The following is a description of a gene set: CD4 T cell help is critical for both the generation and maintenance of germinal centers, and T follicular helper (TFH) cells are the CD4 T cell subset required for this process. SAP (SH2D1A) expression in CD4 T cells is essential for germinal center development. However, SAP-deficient mice have only a moderate defect in TFH differentiation as defined by common TFH surface markers. CXCR5+ TFH cells are found within the germinal center as well as along the boundary regions of T/B cell zones. Here we show that germinal center associated T cells (GC TFH) can be identified by their co-expression of CXCR5 and the GL7 epitope, allowing for phenotypic and functional analysis of TFH and GC TFH populations. Here we show GC TFH are a functionally discrete subset of further polarized TFH cells, with enhanced B cell help capacity and a specialized ability to produce IL-4 in a TH2-independent manner. Strikingly, SAP-deficient mice have an absence of the GC TFH subset and SAP- TFH are defective in IL-4 and IL-21 production. We further demonstrate that SLAM (Slamf1, CD150), a surface receptor that utilizes SAP signaling, is specifically required for IL-4 production by GC TFH. GC TFH cells require IL-4 and IL-21 production for optimal help to B cells. These data illustrate complexities of SAP-dependent SLAM family receptor signaling, revealing a prominent role for SLAM receptor ligation in IL-4 production by germinal center CD4 T cells but not in TFH and GC TFH differentiation. species: Homo sapiens Human Gene Set: GSE21379_WT_VS_SAP_KO_TFH_CD4_TCELL_DN Genes down-regulated in CD4 follicular helper T cells (Tfh) with SH2D1A knockout versus wildtype Tfh cells. from publication Yusuf I, Kageyama R, Monticelli L, Johnston RJ, Ditoro D, Hansen K, Barnett B, Crotty S (PMID 20525889), and this is the list of marker genes: ZBTB20 (zinc finger and BTB domain containing 20), LIG3, CAPSL, LDHB, CD86, BAMBI (NCBI Gene Id 25805), NR3C2, RNF144A, ATF7IP (activating transcription factor 7 interacting protein), UNC5CL, DPP4, B3GNT5 (UDP-GlcNAc:betaGal beta-1,3-N-acetylglucosaminyltransferase 5, NCBI Gene Id 84002), HLA-DRB1, STING1 (NCBI Gene Id 340061), RNF122, STOX2, ZNF329, GCNT1, CENPV, MYL10, TMEM74, PNISR, ELL, TRPV2, ARHGAP30, GLRX, RUNDC3B, NEDD9, GRIA3, TOX3, CLCF1, CILK1, PRR13, MAT2A, TIMP2, VNN1, GIMAP7 (GTPase, IMAP family member 7), RNF217, NECAB1, ADGRL1, SHISA5, RHOQ, NPAS3, GCSAM, REPS1, LTB, MX2, CFTR, MAF, ZBTB16, CD163, CCL5, SPATA13, CYP4V2, ENSG00000267882, MFSD8, IL16, FRYL, NCF4, SELL, OSGIN2, ANXA9, SFI1, PPP6R3, CD1D, EPHA6, FZD6, IRF5, IGF2R, TSC1, ST6GALNAC5, ITGB7, CNGB3, ZFP2, CHD6, PEAK1, HSD17B7, NDN, PML, JADE2, VASN, HSH2D, LMOD3, ICAM1, SIPA1L3, ANKRD39, CCL4, FSD2, MS4A6A, RSF1, RGS2, OASL, IFI44, CD244, AMY2A, GIGYF1, FAM110B, NCOA1, FNBP1, MMP11, BEND5 (NCBI Gene Id 79656), CYRIA, IFIT1, RTP4, MCOLN3 (NCBI Gene Id 55283), NLRP10, KCNQ5, NRXN1, KMT2A, PADI4, KLHL4, ADGRG6, RAI1, TTC19, CD52, SNX29, PDP2, GRB10, HNF4A, CNRIP1, HLA-DQA1, NOTCH2, KIF21B, RELB, UBP1, ZBTB4, TTC12, DNAH8, RSAD2, SYNE2, SCUBE3, RINL, CDK12, IGKC, TRAF3IP2, SLC35D2, IGDCC4 (immunoglobulin superfamily DCC subclass member 4), MLPH, AFP, GBP6, HAPSTR1, OSBPL3, PHF21B, CAMK1D, NEFH, BACH1, IKZF1, IFIT1B (interferon induced protein with tetratricopeptide repeats 1B), MIR99AHG, ACOT11, AIRN, NBEA, CREBRF, MDGA2, CPN2, PIK3C2A, BRDT, RPL34, JCHAIN, SNHG8, CDC14B, TMBIM4, CCDC25, FBXW4, GIT2 (GIT ArfGAP 2), LGALS4, HLA-DOB, MPPED2, ERN1, CHDH, LINC00511, CLNK, PLAC8, NECTIN4, CCN3, GBP7, MARCKS, BCORL1, DMXL2, MC5R, LPIN1, AK4, HLF (HLF transcription factor, PAR bZIP family member), IFI27L2, PINK1, NLGN2, TNFRSF18, IFFO2, CXorf58, LHCGR, WDR35, TRIB2, ZER1, TPST1, TRIM2, C5orf46, RRM2B, CFAP210, PITPNC1